The following is a description of a gene set: part of: Biosynthesis of specialized proresolving mediators (SPMs) This event has been computationally inferred from an event that has been demonstrated in another species.<p>The inference is based on the homology mapping from PANTHER. Briefly, reactions for which all involved PhysicalEntities (in input, output and catalyst) have a mapped orthologue/paralogue (for complexes at least 75% of components must have a mapping) are inferred to the other species. species: Mus musculus Reactome Pathway: Biosynthesis of DHA-derived SPMs electronically inferred by orthology from the curated human pathway, and this is the list of marker genes: Cyp2d22, Cyp2e1, Cyp2c66, Cyp3a13, Cyp2c65, Cyp3a16, Ephx2, Alox12, Cyp1a1, Cyp3a11, Cyp3a57, Gpx4, Cyp3a44, Cyp3a41a, Alox15, Ptgs2, Ltc4s, Cyp1a2, Cyp3a25, Lta4h, Cyp3a41b